Given this list of marker genes ACSS1, TTC4, SCAF4, MCRIP1, IFITM10, ANXA2, PNLIPRP2, MRTFB, ILKAP, CXCR6, WFIKKN2, RNF125, KIF5A, RUNX3, SWAP70, THAP1, DENND4A, L1TD1, PPP2R5A, ZNF169, RRM2B, BTD, MTARC2, AKTIP, NKAP, TRAPPC8, NFATC3, ITGA4, NAPEPLD, FRY, PDCD4, TFAP4, DCAF5, PURG, SSX2IP, DKKL1, CDKN1B, ARHGAP26, ITGB7, MAPK14, OTULIN, PLCXD2, ATP8B4, C2orf76, NBEAL2, ERRFI1, THBS3, RAP2B, STK10, PGS1, EOMES, KAT14, FOXO1, TMEM234 (transmembrane protein 234), SCML4, LPAR6, KYAT1, COG8, GPR132, SETX, SFT2D2, SLC4A11, JUP, TMCO3, PAXX, L1CAM, GTF2E1, TCOF1, MIDN, STK11IP, DDX5, DNAJC15, SH2D3C, SARAF, SETDB2, MACIR, SLC17A9, KLRC1, SLC20A1, KMT2E, TRIB2, IGF2R, GMFG, MYO3A, DUSP7, RIPOR2, CRIP2, NOTCH2, SIRT1 (sirtuin 1), SEMA4A, HERC4, RARA, TAPT1, AP3S1, AQP8, ADGRE5, MARK2, CEP44, STK11, TAF8, KANSL3, ZNF420, GRAMD2B, TUBGCP3, ERG28, CHD2, ZFYVE1, UQCC3, CS, FAM76B, ARX, MPPE1, HS3ST3B1, MROH1, CHSY1, AMER1, NR1H2 (nuclear receptor subfamily 1 group H member 2), ADSS2, CLIC1, TDRP, CATSPERD, HLA-A, MED13, IFNGR1, KLF3, BTG1, MFNG, TTC23L, RO60, DYNC1H1, TBX21, TP73, UBE2W, POLR1F, S1PR4, FLI1, LEMD3, DCUN1D2, CNOT6L, RBM48, TTC7A, ETS1, ANXA6 (NCBI Gene Id 309), SPRING1, FAM89B (NCBI Gene Id 23625), STK38, VPS28, CRLF3, MGAT1, EPS15, PDE4B, POMT1, PRR14, HPS4 (NCBI Gene Id 89781), ZNF394, ATAD1, UBE2E3, ZNF213, TXNIP, WDR89, RHBDD1, IL18RAP, CHD7, TAF4B, PPM1H, TENT5A, OTULINL, PRRT1, PBRM1, MS4A6A, ZNF347 (NCBI Gene Id 84671), GSK3B, PACC1, KIF1B, FBRS, MAD2L2, TEX264, PIP4K2B, ESRP2, XRN2, GPC1, MICAL1, ALKBH7, AGPAT5, FOXP1, MYO1H, MKKS, CDC20B, MANBAL, EIF1, S100A13, GRB10, ADAMTS16, SIDT1, GZMB, CHM, GOLM1, ESYT1, WWP1, CREBZF, here is a description of the gene set: The two major human gd T cell subsets, Vd1 and Vd2, display differences in tissue tropism and agonist responses, but we have little insight into global differences that may exist at the gene expression level. This is due to the small numbers of these cells that can be obtained from healthy donors, which limit comprehensive, comparative gene expression analyses. We established a culture method that expands Vd1 and Vd2 cells from the same PBL preparation to levels sufficient for sorting and microarray analysis. Although the subsets were expanded identically (anti-TCR mAb, plus IL-15), 392 and genes were identified, which were differentially expressed in the two subsets, from two donors, respectively. Approximately genes changed in both subsets following PMA/ionomycin treatment; about 50% of these genes were subset-specific. Both subsets responded to a crude LPS preparation, but only 6% of the responsive genes were the same. The differentially expressed genes were consistent with Vd2 cells being more inflammatory and Vd1 cells having more of a regulatory phenotype. Both subsets expressed transcripts encoding an array of innate and NK cell receptors, supporting the relationship of gd T cells to the innate immune system. Our results show that circulating Vd1 and Vd2 subsets in humans have considerable, inherent differences in gene expression following treatment with non-TCR agonists, supporting unique functional roles for these cells in vivo. Human Gene Set: GSE3720_UNSTIM_VS_LPS_STIM_VD1_GAMMADELTA_TCELL_UP from publication Kress E, Hedges JF, Jutila MA (PMID 16423401) Genes up-regulated in Vd1 gamma delta T cells: untreated versus LPS. studied in species Homo sapiens